The following is a description of a gene set: Human Gene Set: REACTOME_TRAFFICKING_AND_PROCESSING_OF_ENDOSOMAL_TLR studied in species Homo sapiens Trafficking and processing of endosomal TLR, and this is the list of marker genes: TLR7, CNPY3, TLR8, CTSS, CTSL, HSP90B1, CTSV, CTSK, TLR3, UNC93B1, CTSB, TLR9, LGMN